Given this list of marker genes Cbfb, Runx2, Rbm14, Smad1, Ar, Smad4, here is a description of the gene set: studied in species Mus musculus Mouse Gene Set: REACTOME_RUNX2_REGULATES_BONE_DEVELOPMENT RUNX2 regulates bone development